The following is a description of a gene set: An abnormality of the midbrain, which has as its parts the tectum, cerebral peduncle, midbrain tegmentum and cerebral aqueduct. species: Homo sapiens Human Gene Set: HP_ABNORMAL_MIDBRAIN_MORPHOLOGY Abnormal midbrain morphology, and this is the list of marker genes: CEP120, STIL (STIL centriolar assembly protein), DISP1, SNCAIP, CEP41, KIF7, TBCE, LRRK2, SUFU, ADH1C, SLC35A2, TMEM216, GLI2, B9D2, TMEM218, IMPDH2, CEP290, PIBF1, MAPT, ARL3, TCTN1, SHH, WDR45, TMEM237, AHI1, VPS41, TGIF1, RPGRIP1L, ATXN8OS, SIX3, INPP5E, PDE6D, SPG11, FBXO7, ATXN2, SLC44A1, ATXN3, TMEM107, FGF8, CPLANE1, PRKN (parkin RBR E3 ubiquitin protein ligase), KIAA0753, CDON, GTPBP2, MT-TT, PTCH1, C2CD3, NODAL, BRF1, CRIPTO, GBA1, CC2D2A, DLL1, GAS1, TMEM67, NPHP1, ZNF423, OFD1, EXOC2, TOPORS, ARMC9, ZIC2, GCH1, IFT74, ATP7B, FOXH1, TCTN3, ARL13B, TBP, FAM149B1, GALC, NR4A2, FTL, CEP104, TOGARAM1, SNCA, B9D1, MKS1, CSPP1, KIAA0586, TMEM138, TMEM231